The following is a description of a gene set: studied in species Mus musculus from publication Chen Y, Wang X (PMID 31504780) Genes predicted to be targets of miRBase v22 microRNA mmu_miR_3085_5p in miRDB v6.0 with MirTarget v4 prediction scores > 80 (high confidence targets). Mouse Gene Set: MIR_3085_5P, and this is the list of marker genes: Prkd3, Ndnf, Fasl, Ncam2, Dbndd1 (NCBI Gene Id 72185), 4930480E11Rik, Septin8, Smpx, 1600012H06Rik, Ccdc126, Arhgap1, Kank2, Dhx35, Dsel, Rora, Tmprss12, Golph3 (NCBI Gene Id 93791), Cdk12, Tbpl1, Sox8, Pgap6, Amotl1, Tpm4, Pitpnm3, Pip5k1c, Bcap31, Mfhas1, Tspyl1, Pigu, Krtap20-2, Klk5, Klf12, Mfng, Mrpl15, Armh3, Sox6